Given this list of marker genes CRPPA, SIX6, POLR3A, RNU4-2, EXOC2, ATAD3A, SNAP29, PRPS1, HESX1, MAFB, FANCI, RNF113A, POU1F1, APC, PTF1A, GLYCTK, POMT2, GLI2, KMT2D, PHOX2A, FOXA2, IFT74, GDF6, TRIT1, GNPAT, CEP85L, ZFX, ZIC1, RNF135, ARSL (arylsulfatase L), SON, GDF3, ARMC9, MBTPS2, STAG2, FANCB, PAX6, GPR161, FKTN, SPOP, TUBB3, SOX2 (NCBI Gene Id 6657), LHX3, SRD5A3, CACNA1C, AASS, SALL4, RSPO2, PPP2R1A, SETD2, EIF4A2, MED12, ARNT2, FDFT1, PUF60, CENPF, ANKRD11, CDON, HMBS (NCBI Gene Id 5448), PIK3CD, RECQL4, POMT1, PTPN23, SCN8A, ERF, TBX4, SOX3, MAP2K2, ASNS, KNSTRN, TUBA8, NDE1, MEF2C, ALDH1A2, B3GALNT2, KIF14, PLXNA1, RFX7, FGFR1, GABBR1, MACF1 (microtubule actin crosslinking factor 1), GATAD2B (GATA zinc finger domain containing 2B), NFIX, CASK, DDHD2, GMPPB, POMK, PPP1CB, ZPR1, PROP1, WT1, OTUD5, POGZ, YME1L1, TRIM44, KIF21A, WDR11, TUBA1A, HNRNPU (NCBI Gene Id 3192), PROKR2, RTTN, WNT3, OTX2, LAMB2, DNMT3A, ALDH1A3, HNRNPK, FZD5 (NCBI Gene Id 81561), CDC42BPB, ROBO1, FOXC1, FKRP, NR2F1, LARGE1, TUBB2B, KCNK4, NEFL, SNF8, ZSWIM6, LHX4, RERE, CHN1, GRIA4, RRAGC, KDM6A, POMGNT1, COL25A1, MAB21L1, here is a description of the gene set: studied in species Homo sapiens Aplasia/Hypoplasia of the optic nerve Human Gene Set: HP_APLASIA_HYPOPLASIA_OF_THE_OPTIC_NERVE